The following is a description of a gene set: Genes having at least one occurrence of the motif TGAMCTTTGMMCYT in the regions spanning 4 kb centered on their transcription starting sites. This matches the HNF4A transcription factor binding site V$COUP_01 (v7.4 TRANSFAC). Human Gene Set: COUP_01 species: Homo sapiens, and this is the list of marker genes: APOM, ASGR2, ADRA1A, PDE3B, BRPF1, MIEF1, PRKRA, MARCKSL1, PLPPR1, CRABP2, STOML2 (stomatin like 2), FGFR3, MXI1, VEGFA, ESRRG, POU5F1, NEUROG2, GPAT3, EFNB3, TPM2, NR4A3, ZNF436, LYSMD1, PRR7, SELENOM, RBP2, KCNE5, MLST8, ASXL1, PPARGC1A, PRDM16, DAB2IP, NRP1, LMX1B, GYS2, FAM170A, GJB2, ZFHX3, PTH1R, PPP4R3C, TTC19, TP53BP1, MBD5, SERPIND1, PHB2, AP1B1, PPP2R5D, MLLT10, PURA, PABPN1, NUDCD1, PON1, ADRB2, PDGFB, LGALS4, RPL34-DT, SOBP, ZIC4, CRYGC, ZNF436-AS1, DOCK11, USP37, NEK6, SLC26A3, EXD3, TAOK3, PAFAH2, MLLT6, VSX2, LMNA, LGI4 (NCBI Gene Id 163175), RTN2, RNF103 (NCBI Gene Id 7844), ASB7, PKP3, ZNF827, CREB3L3, IL21R, MYBPH, WRAP53, NHERF4, FKBP5, DHRS3, SLC7A7, PITPNC1, ATAT1, OVOL1, WBP4, PNPLA2, PKLR, NCDN, KLC4, FAM20C, PITX2, PPP1R14D, RRBP1, PPP2R3A, OTP, ABI3BP, NR2F1, PCDH7, IRX6, DIS3L, UBE2K, ZPBP2, LZIC, ARHGEF7, CLUH, HOXA10, SMOC1, PLEC, TMEM150A, SMYD5, CFHR1, STEAP2, G6PC1, HPN, SRSF6, MYL11, ZDHHC3, SYMPK, TTI1, C4B, MARK2, TNNI1, ZBTB40, ANGPT1, FABP2, CCDC88B, NDUFS1, PAGR1, CTAGE1, BMF, ODAD3, DDB1, CCDC65, IFFO1, CFHR5, SLC9A3, KYNU, IYD, KIF6, RNF144B, PTMS, NALF2, TPCN1, LTB, FBLN1, LMO3, SHFL, ADGRA2, CDK16, DLX5, AGPS, IQCD, EFNB1, INVS, BPIFA2, PALS1, SORCS1 (sortilin related VPS10 domain containing receptor 1), BOC, TKFC, HBEGF, PRRX2, CSRNP3, CDX1, CIC, TIMELESS, SCNM1, SLITRK2, MAP3K11, JMJD1C, MTTP, HOXA3, NYAP1, TBX5, ALDOA, EXOSC7, PGF, DPF3, NDST2, GMPPB, ARFGEF2, SCFD2, ZNF485, PRKCSH, RBMS1, SHC1, PAX6, CFHR2, HNF1B, SAMD14, EEF1B2, SLC11A2, SNRNP70, MSRB1, ITGA3, TP53, PLA2G12B, GBF1, GATA4, RPRD1B, CREB3L2, FOXA3, SATB1, PSME3IP1, LRFN4, EMG1, BAZ2A, CNIH1, GOLGA4, ZSWIM3, NOXA1, RSPRY1, ACOT7, CUTA, ID1 (inhibitor of DNA binding 1), CNOT9, LMOD3, PPTC7 (NCBI Gene Id 160760), PAK4, CKS1B, HSD17B8, NMNAT1, TMEM40, G0S2, HNF1A, TOMM70, SERPINC1, POLD1, C4A, PAX7, FOXA1, LINS1, RBBP6, MED8, DCTN1, SLC7A9, GAPDH, TNFRSF12A, TRAF4, DNMT3A, ACOT8, ATF4, NDUFA3, DNAJA2, KLHL1, HAS1, ALDH6A1 (NCBI Gene Id 4329), MREG, NR2F2, RTP3, DMD, NET1, DUSP3 (NCBI Gene Id 284066), ZBTB18, MTMR4, EDN3, SZT2, FGF12 (NCBI Gene Id 2257), MLEC, RPL34, MRPL2, PRKCD, MED13